The following is a description of a gene set: Human Gene Set: GOCC_VACUOLAR_PROTON_TRANSPORTING_V_TYPE_ATPASE_V0_DOMAIN species: Homo sapiens The V0 domain of a proton-transporting V-type ATPase found in the vacuolar membrane., and this is the list of marker genes: ATP6V0C, RNASEK, ATP6V0D1, ATP6AP2, ATP6V0E2, ATP6V0A1, ATP6V0B, ATP6V0A4, ATP6V0A2, TCIRG1